Given this list of marker genes GABRA3, LAMA3, LAMC2 (laminin subunit gamma 2), ACTG2, HMBS, APRT, CACNA1S, ASXL1, KCNJ18, RASA1, NAB2, CAMK2B, EXT2, BNC2, STAT6 (NCBI Gene Id 6778), ERCC6, VANGL1, ALDH18A1, PRNP, LAMB3, LMNB1 (NCBI Gene Id 445266), EXT1, SP110, ABCD1, ALMS1, TGFB1, ERCC8, here is a description of the gene set: Inability to completely empty the urinary bladder during the process of urination. studied in species Homo sapiens Urinary retention Human Gene Set: HP_URINARY_RETENTION